The following is a description of a gene set: Mouse Gene Set: CUI_CDC1_CD27L_RESPONSE_DN from publication Cui A, Huang T, Li S, Ma A, Pérez JL, Sander C, Keskin DB, Wu CJ, Fraenkel E, Hacohen N (PMID 38057668) studied in species Mus musculus Cytokines mediate cell-cell communication in the immune system and represent important therapeutic targets. A myriad of studies have highlighted their central role in immune function, yet we lack a global view of the cellular responses of each immune cell type to each cytokine. To address this gap, the authors created the Immune Dictionary, a compendium of single-cell transcriptomic profiles of more than 17 immune cell types in response to each of 86 cytokines (>1,400 cytokine-cell type combinations) in mouse lymph nodes in vivo. A cytokine-centric view of the dictionary revealed that most cytokines induce highly cell-type-specific responses. For example, the inflammatory cytokine interleukin-1β induces distinct gene programmes in almost every cell type. A cell-type-centric view of the dictionary identified more than 66 cytokine-driven cellular polarization states across immune cell types, including previously uncharacterized states such as an interleukin-18-induced polyfunctional natural killer cell state. Genes negatively differentially expressed in cell type: cDC1 (conventional dendritic cell type 1) upon treatment with cytokine: CD27L in mouse lymph nodes in vivo., and this is the list of marker genes: Kctd12, Zfp36l1, Fos, Fosb, Klf2, Klf6 (NCBI Gene Id 97911), Hspa1a, Dusp1, Hspa1b